The following is a description of a gene set: Genes predicted to be targets of miRBase v22 microRNA mmu_miR_7027_3p in miRDB v6.0 with MirTarget v4 prediction scores > 80 (high confidence targets). Mouse Gene Set: MIR_7027_3P from publication Chen Y, Wang X (PMID 31504780) studied in species Mus musculus, and this is the list of marker genes: Ebf1, Cep350, Cd200r3, Grin2d, Atf7ip, Zbtb2, Usp25, Fbxo34, Foxc2